Given this list of marker genes FBXO15, ITGA6, TPM1, AQP4, MSX1, AP2A2, CACNG2, CSPG4, KCNJ6, KLF4, FOXD3, EVX1, GLRB (glycine receptor beta), SNAP25, OLIG2, FOXA2, TUBB3 (NCBI Gene Id 94749), SOX10, SNAI1, SNAI2, SLC6A1, CNP, GAD1, ALDH1L1, CDH1, GAD2 (glutamate decarboxylase 2), ADRA2B, RBFOX3, KRT15, NANOG, BMP4, GRIN1, GLUL, GLRA1, CDH2, FEV, FUT4, DLL1, NGFR, TWIST1, POU5F1, RIMBP2, ERC1, TBR1, MSX2, HTR5A, GLRA2, RIMS2, DLG1, ADRA2C, GLRA3, ROBO1, UNC13A, SOX9, GPHN, SYP, CHAT, SLC6A3, PPFIA1, NLGN1, FGF4, DCX, PCLO, GRIN2B, NR4A2, BSN, TH, TPH1, HES5, LEF1, ITGB1, TWIST2, AP2A1, LHX1, GLS, HOMER2, PAX3, SLC6A4, GATA6, SLC17A7, NES, SLC1A3, DPPA2, HOMER3, LMX1B, NOTCH1, PECAM1, HES1, FABP7, MOG, ACHE, SOX2, CD34, GABBR2, HNF4A, DPPA3, S100B, SLC6A2, SLC17A6, HES3, GABBR1, SHANK1, MBP, GFAP, MAP2, DLG2, MIXL1, NEFM, SLC1A2, ERAS, SLC18A3, HOMER1, GATA4, DLG3, PAX6, HTR1A, TBXT, NEFL, CLDN11, CD24, SLC6A9, SHANK3, CASK, NODAL, LIN7A, SOX17, ADRA2A, TNC, SLC6A5, ZFP42, DLG4, ESRRB, here is a description of the gene set: Cell lineage map for neuronal differentiation studied in species Homo sapiens Human Gene Set: WP_CELL_LINEAGE_MAP_FOR_NEURONAL_DIFFERENTIATION